Given this list of marker genes ABCC2, ABCC3, ABCC1, ABCC6, ABCC10, ABCC11, ABCC4, here is a description of the gene set: species: Homo sapiens The directed movement of leukotrienes into, out of or within a cell, or between cells, by means of some agent such as a transporter or pore. Leukotrienes are linear C20 endogenous metabolites of arachidonic acid (icosa-5,8,11,14-tetraenoic acid) containing a terminal carboxy function and four or more double bonds (three or more of which are conjugated) as well as other functional groups. Human Gene Set: GOBP_LEUKOTRIENE_TRANSPORT